Given this list of marker genes PLPP3, DNAJC19P7, CDCP2, SLC25A3P1, SSBP3, ENSG00000201003, DMRTA2, NRDC, ZYG11A, GPX7, TTC39A-AS1, MIR4711, MROH7-TTC4, ZFYVE9 (NCBI Gene Id 9372), ACOT11, TUT4, LRP8-DT, MAGOH, RN7SL713P, MIR4422, OMA1, MIR761, PARS2, GLIS1, RN7SL788P, RPS20P5, MIR4781, C8A, CALR4P, COA7, HNRNPA3P12, GAPDHP51, CC2D1B, HMGB1P45, LINC01562, FCF1P6, H3P2, PHB1P3, HIGD1AP11, MROH7, MIR6500, TXNDC12, PGBD4P8, TTC22, PRKAA2, TMEM61, CYB5RL, EEF1GP7, HNRNPA1P6, MIR4422HG, SLC1A7, RPSAP20, DHCR24, TSEN15P2, FGGY-DT, RNU6-969P, RAB3B, ENSG00000295077, LINC02777, ANAPC10P1, TTC39A, PDCL3P6, DMRTB1, CDKN2C, RN7SL290P, RN7SL62P, RPL23AP85, TUBBP10, BTF3L4, C8B, RPS26P15, SLC25A6P3, CYP2J2, RNU7-95P, COX7BP3, TACSTD2, NDUFS5P3, JUN-DT, LINC02808, CZIB, LINC02778, LINC01753, MRPL37, EPS15-AS1, NDC1, SHISAL2A, ENSG00000284645, C1orf87, MIR4421, LINC01755, RNA5SP48, HOOK1, PRPF38A, CZIB-DT, USP24, RN7SL475P, ZYG11B, TXNDC12-AS1, PHB1P12, FAM151A, CPT2, LINC01748, FYB2, MAGOH-DT, DAB1, ORC1, GOT2P1, PCSK9, LINC01767, TTC4, FAF1-AS1, RNF11, LRP8, OSBPL9, LINC02784, RNU6-877P, CIMAP2, RNU6-1026P, BSND (NCBI Gene Id 7809), IFT25, GYG1P3, CFL1P2, ECHDC2, PIGQP1, HNRNPA1P63, RPS13P2, RNU6-1281P, LDLRAD1, PLA2G12AP1, MRPS6P2, RNU6-830P, DAB1-AS1, FAF1, TCEANC2, MTCO2P34, RRAS2P1, SCP2, ENSG00000284601, ENSG00000212624, RN7SKP291, MYSM1, KTI12, LINC02812, SSBP3-AS1, RPL21P23, JUN, C1orf185, DIO1, LRRC42, FGGY (NCBI Gene Id 55277), RNU2-30P (RNA, U2 small nuclear 30, pseudogene), DHCR24-DT, EPS15, PODN, TMEM59, YIPF1, here is a description of the gene set: studied in species Homo sapiens Human Gene Set: chr1p32